The following is a description of a gene set: Aside from Myc-activating translocations characteristic of plasmacytomas (PCT), little is known about genetic factors and signaling pathways responsible for the development of spontaneous B-cell lineage lymphomas of mice. Here, we characterized the transcriptional profiles of PCT, centroblastic diffuse large B-cell lymphomas (CBL), and high-grade splenic marginal zone B-cell lymphoma (MZL++) using high-throughput quantitative reverse transcription-PCR. Expression profiles of CBL and MZL++ were strikingly similar and quite unlike that of PCT. Among the genes expressed at significantly higher levels by PCT were a number involved in NOTCH signaling, a finding supported by gene set enrichment analyses of microarray data. To investigate the importance of this pathway, NOTCH signaling was blocked in PCT cell lines by treatment with a gamma-secretase inhibitor (GSI) or transduction of a dominant-negative mutant of MAML1. These treatments resulted in reduced expression of NOTCH transcriptional targets in association with impaired proliferation and increased apoptosis. GSI treatment of transformed plasma cells in a primary PCT also induced apoptosis. These results integrate NOTCH activation with oncogenic signaling pathways downstream of translocated Myc in the pathogenesis of mouse PCT, two signaling pathways also implicated in development of human multiple myeloma and T-cell lymphoblastic lymphoma. Cluster 5 of genes distinguishing among different B lymphocyte neoplasms. studied in species Mus musculus from publication Shin DM, Shaffer DJ, Wang H, Roopenian DC, Morse HC 3rd (PMID 19010892) Mouse Gene Set: SHIN_B_CELL_LYMPHOMA_CLUSTER_5, and this is the list of marker genes: Cdk4, Il6, Hoxd1, Bcl3 (B cell leukemia/lymphoma 3), B2m, Il21, Tnf, Cebpb, Ly6a, Gfi1, Vpreb1a, Rag2, Rasgrf1, Socs3, Fgf4, Vpreb1b, Ifna1, Hoxa9, Ciita (class II transactivator, NCBI Gene Id 669998), Hmgb2